The following is a description of a gene set: species: Homo sapiens Post-translational modifications of circadian clock proteins provide additional levels of tempo control and metabolic control, as well as mechanisms for terminating transcriptional activation and activating proteolysis.<br>After BMAL1 (ARNTL) and CLOCK are synthesized in the cytosol, CDK5 phosphorylates CLOCK (inferred from mouse homologs in Kwak et al. 2013) and CSNK2A1 (CK2alpha) phosphorylates BMAL1 (inferred from mouse homologs in Tamaru et al. 2009, Tamaru et al. 2015). The phosphorylated BMAL1 and CLOCK proteins heterodimerize (inferred from mouse homologs in Kondratov et al. 2003, Tamaru et al 2015) and are translocated to the nucleoplasm (inferred from mouse homologs in Tamaru et al. 2003, Kondratov et al. 2006, Kwon et al. 2006). NPAS2 can also heterodimerize with BMAL1 and is presumed to undergo similar phosphorylation, however, this has not been directly demonstrated. Reactome Pathway: Phosphorylation and nuclear translocation of BMAL1 (ARNTL) and CLOCK part of: Circadian clock, and this is the list of marker genes: CSNK2B, CSNK2A1, CDK5, CLOCK, BMAL1